Given this list of marker genes Mir9-2, F2, Lrg1, Tmem176b, Nckap1l, Zfpm1, Ppp1cc, Skic8, Sema3a, Supt6, Spry2, Nog, Ednrb, Chodl, Lag3, Ski, Cd101, Acvrl1, Clec4g, Wnt4, Smarcc2 (NCBI Gene Id 68094), Hdac4, Twist2, Ctnna1, Lrp8 (low density lipoprotein receptor-related protein 8, apolipoprotein e receptor), Pithd1, Ephb1, Olfm1, Prom1, Dusp10 (NCBI Gene Id 98270), Tcf23, Itgb1, Myog, Lmod3, Anxa1, Emp2, Bhlha15, Marcks, Acvr1, Drd2, Mcub, Il1rl2, Smo, Mir154, Dkkl1, Gas6, Fuom, Bmp7, Trpv1, Ikzf1, C1ql4 (complement component 1, q subcomponent-like 4), Anapc2, Inpp5d, Klf13, Dct, Hmg20a, Kdm1a, Mbd1, Cmklr1, Mbd3, Il2, Ywhah, Agtr1a, Kit, Sema4d (NCBI Gene Id 20354), Apob, Bhlhb9, Bbs12, Shox2, P2ry12, Capn3, Prkci, Nsun2, Il2rg, Hes5, Ctla4, Foxp3, Prkaca, Il17d, Smoc1, Id2 (NCBI Gene Id 97802), Mettl3, Hax1, Ptpra, Asb4, Hspb1, Stat5a, Btg2, Zfp418, Mir30c-2, G6pdx, Cyp27b1, P4htm, H3f4, Scube2, Notch1, Fnip1, Ace, Dll3, Pcm1, Metrn, Khdc3, Lmna, Mir205, Runx3, Bhlhe41, Prmt3, Dusp15, Xdh, Fgfr1, Sh3gl3, Rnf6 (NCBI Gene Id 74132), Mapk8, Cpne1, Mir669a-9, Smarcd1, Eif4g2, Smad9, Atg7, Trpv4, Clec2g, Nfe2l2, Rab7b, D130043K22Rik, Rufy3, Fgf2, Slit1, Ptprf, Duxbl1, Setd1a, Il33, Ldb1, Daam2, Xrcc5, Zfp219, Cd4, Mir9-3, Acin1, Smad3, Meis1, Braf, Socs1, Hoxa7, Mbp, Ltk, Ctf2, Ankrd27, Alox5, Six3os1, Dpysl5, Ccn2, Akirin1, Mpl, Il20, Kat7, Cask, Hif1a, Trak1, Nkx2-2os, Slc25a4, Maff (NCBI Gene Id 17133), Ferd3l, Fbxw7, Elf5, Il34, Nbr1, Riox1, Sh3glb1, Ptger3, Tlx2 (T cell leukemia, homeobox 2), Rac3, Brpf3, Cebpa, Cthrc1, Tescl, Hmg20b, Mir7-1, Baiap2, Wnt7b, Loxl2, Trim6, Uchl3, Ptpn11, Prkdc, Daxx, Anp32b, Wnt3a, Spart, Nell1, Sema3f, A430033K04Rik, Ripk1, Vim, Ist1, Tmem176a, Ambra1, Nfkbiz, Atat1, Tox, Ninj1, Ptbp3, Ptpn6, Snw1, Ripor2, Kdm3a, C1qc, Sgpp1, Mboat2, Runx1, Serpinf1, Pira12, Pparg, Snai2 (NCBI Gene Id 20583), Itgam, Lrrk2, Kras, Dbnl, Nr3c1, Nr1d2, Fstl4, Pten, Cdh1, Nphp3, Itpka, Pbrm1, Inhba, H2-DMa, Gorasp1, Notch2, Tgfbr2, Slc4a11, Chrd, Cdk5rap2, Opalin, Rbfox2, Acvr2a, Keap1, Pofut2, Ctla2a, Axin2, Crabp2, Gpr68 (G protein-coupled receptor 68), Spred1, Hes1, Rps19, Zc4h2, Tnfaip6, Ptbp1, Slc6a6, Map6, Pthlh, Lin28a (lin-28 homolog A), Trib3, Smarcc1, Kat2a, Ap3d1, Actr2 (actin related protein 2), Erfe, Ccn6, Sh2b3, Pkdcc, Brd9, Myod1, Parp6, Sfrp4, Nr2c2, Npr2, Lgals1, Ddx6, Cysltr2, Tbx19, Klf4, Sox13 (SRY (sex determining region Y)-box 13), Mex3c, Actl6a, Igf2, Igfbp5, Numb, Tgfbr1, Ush2a, Apoe, Gpc1, Efemp1, Zfp35, Wdr1, Klhl41, Dixdc1, Sp7, Pitx3, Abca12, Mapk14, L3mbtl1, Caprin2, Hey1, Pglyrp2, Tnfrsf12a, Vcl, Fancd2, Zfp932, Gdf3, Senp1, Slc6a4, Wnt10b (NCBI Gene Id 22410), Cdk5, Mir338, Rorb, Smurf1, Prpf19, Rnd2, Pwp1, Tbx6, Hspa9, Prdx2, Tgfb3, Flt3 (NCBI Gene Id 269731), Nucb2, Myc, Tomm70a, Gpr171, Hdac5, Hlx, Adipoq, Nppc, Star, Paf1, Stk4, Rgs14, Spsb3, Nr2e1, Grn, Vegfa, Cbfb, Mir133a-2, Eif4g1, Lgals9, Atf4, Ep300, Ifi204, Cited1, Tnpo2, Ryk, Casz1, Adamts12 (ADAM metallopeptidase with thrombospondin type 1 motif 12), Megf8, Xlr3b, Carm1, Sinhcaf, Phox2b, Plxna3, Bend6, Il10, Arrb2, Ucma, Kalrn, Mir669a-10 (microRNA 669a-10), Plxnc1, Btn2a2, Tmem178, Foxp1, Fshb, Hand2, Egr3, F11r, Zfp703, Gna11, Rptor, Eng, Bmal1, App, Neurog3 (NCBI Gene Id 216015, neurogenin 3), Dkk1 (NCBI Gene Id 13380), Gdpd2 (NCBI Gene Id 71584), Spen, Bmpr2, Ulk1, Rbm4, Thy1, Bhlhe40, Sox4, Nefl, Ap2a2, Mmp14, Zfpm2, Tcf15, Cds1, Nedd9, Dlx2, Ntrk2, Il2ra (interleukin 2 receptor, alpha chain), Akap5, Sox1, Ttpa, Yap1, Cth, Prkch, Clock, Ptprc, Trf, Eif4e, Irgm1, Eppk1, Mbnl3, Nlrp3, Klhl25, Notch4, Ifitm1 (NCBI Gene Id 68713), Prdm6 (PR domain containing 6), Appl2, Pias3, Insig1, Rgs6, Lrp1, Mta2, Htr2a, Pdcd4, Spi1, Zmiz1, Nfam1, Vezf1, Bcl7b, Zfp609, Rbm38, Pdlim7, Fgf9, Fezf2 (NCBI Gene Id 54713), Ascl2, Dact3, Iqcb1, Trip4, Ccr7, Syap1, Kdm4c, Zbtb1, Bin1, Pira1, Trak2, Adra2c, Megf10, Cdkn1c, Oog1, Vhl, Dpf3, Trim32, Dtx1, Sema5a, Usf3 (NCBI Gene Id 74501), Tsc2, Eya1, Tnr, Lhx2, Dubr, Mir212, Mir669a-5, Adamts9, Hemgn, Slc45a3, Mecom, Cdx2, Col5a2, Ascl1, Mosmo, Cntn4, Mir124a-2, Gcnt2, Mt3, Itgb3, Camk1, Kat6a, Mir204, Ccl19, Ccl3, Six3, Prtg, Actl6b, Kcnk18, Gdf10, Fermt2, Nbl1, Trim72, Ahi1, Hdac2, Sox8, Fbxo5, Mir133a-1 (NCBI Gene Id 387151), Twist1, Ift88, Kdr, Glipr2, Hmgb2, Osr1, Uncx, Ddrgk1, Mesp1 (mesoderm posterior 1), Cd1d1, Abcb1a, Wdfy2, Mad2l2, Nos1, E2f1, Lnpk, Tsc22d1, Hif1an, Rbbp4, Asxl2, Zfp36l1, Mtch2, Cul7 (NCBI Gene Id 66515), Brinp1, Csf2, Dock7, Idh2, Rarres2, Ankrd2, Adnp, Cftr, Smarca2, Cxcr4, Bmp10, Akap11, Reck, Spint1, Bloc1s6, Ncor2, Cdk12, Ccnd2, Ceacam1, Hspa1b, Rap1a, Man2a1, Ccn4, Cd83, Tnn, Mir669a-2, Akt1 (NCBI Gene Id 268604), Asxl1, Ptk2, Cd27, Rflnb, Hoxd11, Apcs, Fbxo31, Ccl21b, Nkap, Sostdc1, Ufl1, Arhgap32, L1cam, Plcb1, Pf4, Foxe3, Pou4f1, Ostn, Bag1, Nap1l1, Fas, Wnt5b, Mir188, Btc, Jun, Reg3a, Rflna, Pramel1, Rnf41, Pias1, Islr2, Cntn2, Sult2b1, Glg1, Ptpn2, Npnt, Aurka, Socs3 (NCBI Gene Id 12702), Ptprd, Csrp3, Rnf112, Cartpt, Itgav, Suco, Hsp90ab1, Il3, Taf8, Acvr1b, Gsk3a, Rag2, Draxin, Calr, Prickle1, Dnmt3b, Hdac1, Gps2 (NCBI Gene Id 56310), Mag, Dmpk, Areg, Pkp2, Ripk2, Stau2, Epha4, Ephb2, Nkx6-2, Mir223, Kif14, Cib1, Lig4, Zeb1, Chd5, Acvr2b, Mir125a, Rras, Cldn5, Zfp36, Disp3, Ybx1 (Y box protein 1), Pde5a, Ccn3, Ypel4, Gpr37l1, Trpc6 (NCBI Gene Id 22068), Wnt9a, Gdf11, Tmem64, Pin1rt1, Aamdc, Cd34, Gli3, Adgra2, Il7r, Foxa1, H2-M3, Lamb1, Slc46a2, Il17a, Lbx1, Mkx, Zbtb7c, Gdf5 (NCBI Gene Id 228821), Ywhag, Trp63, Zcchc24, Pck1, Ccdc85b, Mixl1, Adamts7, Upf3b, Ociad1, Eef2k, Wnt3, Adra2b, Fst, Tspo, Foxn1, Ahr, Tnfsf11, Trim62, Ada, H2-Aa, Rbm24, Spag9, Tcta, Hoxb4, Rassf2, Chadl, Jag1, Myo5b, Nr1d1, Brinp2, Serpine2, Lrp3 (low density lipoprotein receptor-related protein 3), Rarg, Vsir, Ocstamp (NCBI Gene Id 74614), Parp1, Mettl14, Cdk13, Efemp2, Bnc1, Cnot4, Cux1, Mdk, Setd3, Ovol2, Bmp2, Mta1, Nanog, Smyd1, Gata1, Mysm1, Apbb1, Scin, Jak3, Mta3, Klf5, Pawr, Mstn, Fzd1 (NCBI Gene Id 14362), Chd7, Sox6, Fstl3 (NCBI Gene Id 83554), Evi2b, Mir219a-2, Abcb10, Rcor1, Rab21, Tnfrsf11b, Gata3, Kat6b, Btg1, Tacstd2, Skil, Tert, Atoh1, Amigo1, Noct, Sox9, Mir124a-1, Cfl1, Cdk9 (cyclin dependent kinase 9), Ccdc3, Clasp2, Cmtm5, Trib1, Fadd, Atp11a, Ccr2, Nptn, Rela, Mmp11, Lmo2, Shtn1, Parp2, Ppp2ca, Tnfrsf11a, Sh3rf1, Tfap2a, Vax1, Tob2, Gh, Faim, Sdhaf2, Epha7, Bmp4, Rpl4, Cdkl3, Tbc1d24, Neurod1, Il21, Neurog2, Id3, Trpm4, Ddx5, Rgma, Etv5, Gabpa, Ddx39b, Tarbp2, Tenm4, Ptn, Oprm1, Egr2, Dll4, Oog3, Adam8, Tmem100, Frs2, Smarca4, Sirt1, N4bp2l2, Mir124a-3, Cldn18, Ifrd1 (interferon-related developmental regulator 1), Bcl7a, Rhoh, Nfkb1, Eif2ak2 (eukaryotic translation initiation factor 2-alpha kinase 2), Extl3, Tgfb1 (NCBI Gene Id 21803), Ramp2, Grem1, Tnfsf14, Pax2, Hbp1, Runx1t1, Fosl2, Ccl8, Igf1, Smad6, Stat5b, Gdi1, Rest, Tgm2, Gsx2, Cdk6, Foxa2 (NCBI Gene Id 15376), Rbpms2, Adamts20, Gata2, Slamf8, Clcn2, Pou4f2, Mmd2, Hoxd3, Ppp3ca, Robo2, Ctnnb1, Atoh8, Tcf12 (NCBI Gene Id 319985), Bambi, Tlx3, Sorl1, Trim11, Fdps, Pla2g5, Sox5, Slc30a1, Bmpr1b, Smarcd3, Cyp26b1, Por, Lpl, Nmrk2, Pde3a, Fam210b, Dleu2, Hook3, Commd5, Pax6, Tbx20, Maml1, Ccn5, Zbed6, Cela1, Dicer1, Sema6c, Trp53, Skint1, Trpv2, Dnmt1, Golga2, Rbbp7, Stk25, Numa1, Pla2g3, Phldb1, Vwc2l, Fuz, Phldb2, Rc3h2, Stat3, Fbn2, Cdkn1b, Plxnb1, Tcp11x2, Nox1, Zap70, Xrcc4, Carmil2, Kitl, Nkx2-5, Cx3cl1, Trip10, Ptprs, S100b, Ddit3, B2m, Trim58 (NCBI Gene Id 386443), Rorc, Agtr1b, Tcim, Mup20, Bcl11b, Rarb, Tiam1, Kat5, Gatad2b, Slc9b2, Ctr9, Etv2, Bcl6, Leo1, Hmgb3, Tnfsf9, Ppard, Arid2, Klf10, Boc, Shb, Bcl2, Syk, Lta, Ifng, Foxg1, Nkx6-3, Smad2, Arhgap4, Il36g, Mmp9, Mib1, Xrcc2, Glis1, Sema4f, Hdac7, Ankrd54, Sod2, Slitrk1, Ajap1 (NCBI Gene Id 433810), Gnas, Trps1 (transcriptional repressor GATA binding 1), Cysltr1, Ikzf3, Hsf1, Ndel1, Vsx2, Smad7, Fndc5, Tal1, Nrdc (NCBI Gene Id 76534), Macf1, Jund, Dhx36, Il6st, Dip2b, Rbm10, Ankrd17, Ulk2, Gatad2a, Actb, Zfyve27, Rgs2, Lrp5, Esrp1, Gprc5b, Dmrta2, Dact1, Lpin1, Mycl, Srsf6, Il4ra (NCBI Gene Id 16190), Uqcc2, Bex1, Cyp51, Dsg2, Ffar4, Cdh4, Mycn, Mir219a-1, Dlx5, Hes7, Mustn1, Prmt5, Flot2, Pnp, Smap1, Hmga2, Lrp6, Fxr2, Met, Ccr5, Sra1, Nbn, Nfatc3, Dlk1, Psen1, Flt1, Syngap1, Sik1, Wdr62, Edn3, Rgcc, Atp11c, Cux2, Mtor (mechanistic target of rapamycin kinase), Tph1, Mir214, Loxl3, Hoxa5, Epha3, Wls, Wnt7a, Cd24a, Mir301, Hsp90aa1, Fezf1, Fzd7, Tob1, Cav1, Kifap3, Medag, Hoxa9, Mafb, Lama2, Epc1, Mir133b, Golga4, Plxnb2, Sfrp2, Creb1, Sema3g, Col1a1, Limk1, Prelid1, Dab2ip, Myrf, Glul, Nrp1, Wnt2, Tnf, Cd109, Cebpd, Mapk1, Sirt6, Dnai3, Vasn, Znhit1, Myocd, Ezh2, Tgfb2, Fanca, Ihh, Bdnf, Siglec15, Ache, Brinp3, Helt, Fgf13, Ccnd1, Pdpn, Wnt9b, Rasgrp1, Pim1, Napepld, Ap3b1, Zfp608, Irf1, Tesc, Tfe3, Tmem98, Cxcl14, Cip2a, Ppara, Impact, Plxnd1, Mir448, Lilrb4a, Lif, Ager, Map1b, Trpc5, Ipo7, Flt3l, Isl1, Mir3960, Ereg, Arid1a, Hey2, Cd46, S1pr2, S1pr3, Ptch1, Pramel7, Wwtr1, Ccn1 (NCBI Gene Id 99596), Ccl9, Ilk, Tcf4, Bicra, Cyld, Robo1, Tcp11, Hdac8, Gcm1, Gdf2, Cntf, Nme1, Cxcl9, Esrrb, Cyfip1, Caprin1, Adcy10, Pax8, Il18, Med28, Gdpd5, Spinkl, Gnb3, Map2, Suz12, Xrcc6, Etv4, Rgs4, Stk11, Clcf1, Tlr9, Rag1, Prlr, Il4, Gfap, Mir669a-8, Ccr1, Dpysl2, Ins1, Lama1, Clec2d, Macroh2a2, Brd1, Nf2, Twsg1, Msr1, Fxr1, H2-Ea, Opa1, Cxcl10, Il1rapl1, Ptch2, Rc3h1, Zfhx3, Srf, Itpkb (inositol 1,4,5-trisphosphate 3-kinase B), Clec12a (C-type lectin domain family 12, member a), Ikbkb, Sfrp1, Isg15, Pglyrp4, Sox11, Il15ra (interleukin 15 receptor, alpha chain), Lef1, Add1, Reln, Mitf, Pglyrp3, Ect2, Ccl11, Smarce1, Ranbp3l (RAN binding protein 3-like), Actn3, Gja1, Myb, Med1, Wee2 (NCBI Gene Id 381759), Eid2b, Fbxo7, Macroh2a1, Errfi1, Twf2, Abcc8, Mir217 (NCBI Gene Id 387213), S1pr5, Fgfr2, Esrra, Dlg4, Cx3cr1, Foxa3, Tnik, Alx1, Jdp2, Ror2 (NCBI Gene Id 26564), Six2, Krt84, Krt36, Mamstr, Yy1, Morf4l2, Csf1 (colony stimulating factor 1 (macrophage)), Lbh, Camk2b, Fgl2, Zfp750, Nkx2-2, Zdhhc21, Insm1 (insulinoma-associated 1), Axl, Inpp4b, Srrt, Qki, Car2, Prdm1, Mir210, Map2k1, Rock1, Il12a, Proc, Eif6, Plxnb3, Trp73, Vstm2a, Kctd11, Il1a, Ubash3b (ubiquitin associated and SH3 domain containing, B), Rap1gap, Ins2, Limd1, Clu, Gpr55, Mylk3, Smad5, Ccne1, Neurod2, H2-Oa, Hoxb3, Or10j5, Efna3, Mir30c-1, Map3k5, Cd36, Tle6, Sox10, Fgf23, Cers2, Ppargc1b, Zfp36l2, Reg3g, Sall1, Hltf, Atn1, Sos1, Pus7, Ttc3, Hoxb8, Edn1, Dcx, Olig2, Cebpb, Nodal, Rara, Rbm15, Rac1, Mir135a-1 (microRNA 135a-1), Oog2, Anxa2, Pak1, Nr6a1 (NCBI Gene Id 76667), Tbx5, Enpp1, Hoxa11, Bmyc, Rbp1, Ntf3, Socs2, Efnb2, Ss18, Crp, Nudt21, Gfi1, Gpr137b, Prl2c2, Mir669a-3, Gjc2, Tshz3, Bmpr1a, Dspp (dentin sialophosphoprotein), Serpinf2, Tnfrsf1a, Slc4a2, Tnfrsf21, Efnb3, Ntrk3, Six4, Tnfsf18, Fgf20, Shh, Csf3r, Tgif1, Sdcbp, Il12b, Foxc1, Fmr1, Ell3, Lmo3, Sart1, Alms1, Cd69, Ptger4, Il4i1, Fbxw8, Sox17, Hdac3, Cdkn2b, Grhl1, Rin2 (NCBI Gene Id 99432), Il23a, Il5, Mir9-1, Fbn1, Rcan1, Csf1r, Faxdc2, Klf7, Cdon, Hmgb1, Dnajb11, Zfp365, Tmem182, Abca5, Drd3, Sox21, Lrrc17, Lamb2, Atraid, Brd4, Prxl2a, Akap6, Thpo, Nin, Pth, Tbx3, Trem2, Msx2, Lrp4, Smyd5, Mdm2, Foxj1, Zbtb7b, Nepro, Lamc1 (NCBI Gene Id 226519), Ptprz1, Duoxa1, Lsm1, Tnfsf4, Jade2, Socs5, Sema7a, Map3k13, Apc, Scube3, Rapgef2, Mir132, Eif5a (NCBI Gene Id 28059), Sult1e1 (sulfotransferase family 1E, member 1), Fndc3b, Notch3, Pcp4, Hopx, Alk, Bicral, Tcirg1, Ptprq, Men1, Nid1, Gdf6, Adig, Prdm4, Abl1, Aspa, Mmd, Bmp6, Pax4, Zhx3, Tyrobp, Fto, Zc3h12a, Nfkbid, Hes2, Plpp7, Rnf10, Vnn1, Meis2, Sema6d, Ccl20 (NCBI Gene Id 20297), Ddr2, Cyb5d2, Trp53inp1, Mturn, Gsk3b, Ccr1l1, Efna5, Syt4, Smarcd2, Dlk2, Enpp2, Hamp2, Mir150, Drosha, Tmem53, Rbfox1, Synj1, Clptm1, Hoxa2, Sgk1, Prkd1, Agt, Cit, Gper1, Prkg2, Eif4enif1, Card11, Zbtb7a, Thrb, Mir23a, Fzd4, Lyn, Sirt2, Jak2, Foxo4, Pbx1, Mir675, Igfbp3, Snap91, Wif1, Prmt1 (protein arginine N-methyltransferase 1), Ppp2r3c, Il36b, Neurog1, Uts2, Pdgfra, Tlr2, Lrp2, Adcyap1, Lpar3, Fshr, Hpn, Spry1, Rock2, Abcg1, Tgif2, Ccr6, Crim1, Ltbp3, Atf5, Mir137, Pik3r1 (NCBI Gene Id 328326), Ndfip1, Afdn, Pias2, Lilrb4b, Ing5, Tmem119, Gdnf, Nf1, Htr2c, Dynlt1b, Plekhb2, Nkx3-2, Bcl11a, Pcid2, Zfp683, Heyl, Gimap3, Atxn1, Adrb1, S100a10, Adam7, Maf, Hdac9 (NCBI Gene Id 79221), Dag1, Il7, Pin1, Traf6, Prkcz, Mir669a-1, Meaf6, Bcl9l, Sash3, Rfx3, Foxo1, Xkr8, Slit2, Fgf18, Stk3, Actr3, Foxp4, Lox (lysyl oxidase), Egfr, Smad4, Tiam2, Pdcd2, Foxj2, Sin3a, Nfkbia, Ret (ret proto-oncogene), Otp, Tunar, Pglyrp1, Mir34a (microRNA 34a), Rhoa, Tgfb1i1, Spred2, Tead2, Snai1, Hamp, Myf5, Crxos, Grb14, Lingo1, Pou5f1, Bloc1s5, Glp1r, Mecp2, Prkx, Nln, Gfi1b, Runx2, Adm, Nme2, Cd74, Pi16, Tmsb4x, Piezo1, Shoc2 (Shoc2, leucine rich repeat scaffold protein), Cdc73, Zfhx2, Dmbt1, Ntn1, Zbtb16, Mark1, Ccl5, Mir669a-4, Per2, Crebl2, Lep, Clic1, Phf10, Tcf7, Brd7, Cav3, Ccnk, Tsku, Prox1, Gata5 (GATA binding protein 5), Dpf1, Fam20c, Mcrip1, Brd2, Gli1, Pafah1b1, Tbx1, Id1, Nfe2l1, Iapp, Ar, Apold1, Numbl, Clasp1 (NCBI Gene Id 76707), Ldlrad4, Ctnnbip1, Prkca, Wnt5a, Hap1, Fbxo22, Xbp1, Gpr137, Lhx1, Tmem131l, Ddx17, Nelfb (NCBI Gene Id 99058), Neurl1a, Fat4, Irx3, Pou3f2, Vdr, Rtn4r, Mapt, Ngf, Gnaq, Efna1, Axin1, Erbb2, Lmx1a, Trib2, Adrm1, Ythdf2, Nkx6-1, Akirin2, Crtam, Tgfbr3, Hnrnpu, Tnfrsf1b, Junb, Olfm2, Ncoa3, Grm5, Adgrv1 (adhesion G protein-coupled receptor V1), Nrep, Bcl6b, Zhx2, Rpl3l, Ccl17, Pkp1, Chd4, Timp2, Gdf7, Zfp488, Fgfr3, Plekhb1, Slc7a5, Pik3r6, Metrnl, Shank3, Ankle1, Pinc, Ldlr, Il1b, Tcf3, Rbpj, Crb2, Mapk9, Hes6, Casp8, Six1, Bnip2, Myf6, Fzd3, Mapk8ip3, Rora, Clec2i, Fbxo11, Cul4a, Trio, Fxn, Tcf7l2, Mir669a-6, Kat8, Hcls1, Lck, Bcl7c, Trim46, Neurod4, Sfn, Tespa1, Nfatc1, Nfatc2, Grip1, Rtn4, Cd28, Il15, Cd53 (NCBI Gene Id 99593), Zbtb46, Spred3, Ptgs2, Tent5c, Lrrc8a, Col5a1, Hdac6, Obsl1, Ltf, Malt1, Pilrb1, Rreb1, Rassf10, Tbx21, Alox8, Zfp385a, Tfap2b, Dll1, Cd276, Nap1l2, Nrarp, Gimap5, Tent5a, Cxcl12, Slc7a10, Dpf2, Ankrd26, Mfn1, Zc3h8, Vwc2, Sox2, Dlx1, Il6, Smad1, Sh3pxd2b, Aspm, Aplf, Flcn, Il27, Kdf1, Tjp2, Ccnt2, Mir326, Disc1, Zeb2, Mir100, Nrg1, Id4, Ss18l1, Rb1, Sox12, Dcstamp, Dab1, Stat1, Prdm16, Ptgr3, Foxo3, Vegfc, Map2k2, Eeig1, Cd44, Ngfr, Serpine1, Msx1, Ctdp1, Ifnb1, Kdm4a, Nr5a2 (NCBI Gene Id 52226), Clec7a, Sav1, G6pd2, Thoc5, Frzb, Fgf10, Sort1, Mir669a-7, Ets1, Ctdsp1, Evi2, Csf3, Pa2g4, Grip2, Dmd, Hes3 (NCBI Gene Id 15207), Nfatc4 (NCBI Gene Id 73181), Fes, Spdef, Il17rd, Pdgfb, Dnm1l, Dbn1, Pak3, Cdh5 (NCBI Gene Id 12562), Eif2b2, Cd40lg, Ptk2b, Adipor1, Sox3 (NCBI Gene Id 20675), Mme, Epo (erythropoietin), Bad, Cdkn2a, Neu2, Mfn2, Fn1, Tlcd3b, Smarcb1, Zfp335, Wnt1, Isl2 (NCBI Gene Id 70352), Nlgn1, Dab2, Nkx2-1, Picalm, Prune1, Eif2ak4, Nek5, Cdkl5, Rheb, Mef2c, Plag1, Ncoa1, Tmprss12, Dscam (NCBI Gene Id 78761), Ppp1r13l, Sos2, Zfp536, Gli2, Mafg, Fos, Arhgef2, here is a description of the gene set: studied in species Mus musculus Mouse Gene Set: GOBP_REGULATION_OF_CELL_DIFFERENTIATION Any process that modulates the frequency, rate or extent of cell differentiation, the process in which relatively unspecialized cells acquire specialized structural and functional features.